The following is a description of a gene set: This event has been computationally inferred from an event that has been demonstrated in another species.<p>The inference is based on the homology mapping from PANTHER. Briefly, reactions for which all involved PhysicalEntities (in input, output and catalyst) have a mapped orthologue/paralogue (for complexes at least 75% of components must have a mapping) are inferred to the other species. electronically inferred by orthology from the curated human pathway part of: Signaling by Insulin receptor studied in species Mus musculus Reactome Pathway: Insulin receptor recycling, and this is the list of marker genes: Atp6v1d, Atp6v0e2, Tcirg1, Atp6v1c2, Atp6v0c, Ptpn1, Atp6v1g2, Atp6v1g3, Atp6v0a1, Atp6ap1, Ins1, Atp6v1f, Atp6v1a, Ins2, Ctsd, Ptprf, Atp6v0a4, Atp6v0d1, Atp6v1e2, Atp6v0e